Given this list of marker genes E2F2, CRABP1, MAPK3, ARAF, CDK6, JAK3, RB1, STAT5A, KRAS, PIK3R2, CDK4, CCND1, RXRG, SOS1, FHIT, AKT2, TGFA, MAP2K1 (NCBI Gene Id 5604), STK4, PDK1, CDKN2A, GRB2, GADD45B, E2F1, TP53, BAD, MAP2K2, MAPK1, PIK3CA, CASP8, PIK3CD, POLK, RARB, CASP9, RXRA, CYCS, E2F3, PRKCG, RASSF5, EML4, PIK3R1, GADD45G, EGF, ALK, RAF1, BRAF, CDKN1A, FOXO3, NRAS, CRABP2, PIK3R3, GADD45A, BAX, AKT3, STAT3, HRAS, RXRB, PLCG1, STAT5B, PIK3CB, AKT1, BAK1, ERBB2, PLCG2, PRKCB, CASP3, PRKCA, RASSF1, SOS2, EGFR, BID, DDB2, here is a description of the gene set: studied in species Homo sapiens Non-small cell lung cancer Human Gene Set: WP_NONSMALL_CELL_LUNG_CANCER